Given this list of marker genes NUP42, SP3, IKBKG, NSMCE4A, SP100, HDAC7, TP53, SAFB, RNF2, PHC1, SIN3A, HIC1, RAE1, SMC3, RPA1, MRTFA, NCOA2, NCOR2, BRCA1, NOP58, HDAC1, PHC2, RING1, BLM, CDCA8, L3MBTL2, NFKB2, PGR, H4C1, NUP35, MITF, EP300, CTBP1, RANGAP1, NRIP1, NCOA1, PPARA, IKBKE, SUMO2, SMC1A, NSMCE3, DDX5, NUP88, NR1H2, NSMCE1, WRN, ZNF131, ING2, NUP85, PPARG, CBX2, RAD52, TOP1, FOXL2, CASP8AP2, VDR, NUP37, HIPK2, CDKN2A, HNRNPC, PARP1, RANBP2, TOP2B, AURKA, NR1H4 (NCBI Gene Id 9971), SATB1, HNRNPK, EIF2AK2, SEH1L, HDAC2, NUP107, PCNA, MTA1, SATB2, EID3, THRB, NUP155 (NCBI Gene Id 9631), UHRF2, PML, NR3C2, PARK7, NR5A1, PPARGC1A, NR1I2, TRIM27, NUP50, PIAS1, RELA, PIAS2, DDX17, PIAS4, NR5A2, CETN2, VHL, ZNF350, NUP188, NR1H3, HDAC4, TFAP2C, NUP62, STAG1, AR, NUP210, AURKB, POM121, CBX5, RORA, NUP153, BIRC5, CBX8, TPR, NDC1, NUP93, NSMCE2, THRA, MBD1, NUP58, TP53BP1, NUP214, XRCC4, NR3C1, XPC, NPM1, NUP54, RAD21, CREBBP, DNMT3B, TRIM28 (tripartite motif containing 28), NUP205, SUMO3, CBX4, DAXX, NUP133, STAG2, TOP2A, MDC1 (mediator of DNA damage checkpoint 1), MDM2, TFAP2A, SMC5, BMI1, ZBED1, NR2C1, NUP160, RNF168, INCENP, AAAS, POM121C, DNMT1, NUP43, SUZ12, PCGF2, TOPORS, SCMH1, RXRA, UBE2I, NUP98, SUMO1, SEC13, NR4A2, ESR1, NFKBIA, SMC6, DNMT3A, HERC2, TDG, TFAP2B, PHC3, CHD3, RARA, PIAS3, here is a description of the gene set: SUMO proteins are conjugated to lysine residues of target proteins via an isopeptide bond with the C-terminal glycine of SUMO. Proteomic analyses indicate that SUMO is conjugated to hundreds of proteins and most targets of SUMOylation are nuclear. Within the nucleus SUMOylation targets include transcription factors (TFs), transcription cofactors (TCs), intracellular (nuclear) receptors, RNA binding proteins, RNA splicing proteins, polyadenylation proteins, chromatin organization proteins, DNA replication proteins, DNA methylation proteins, DNA damage response and repair proteins, immune response proteins, SUMOylation proteins, and ubiquitinylation proteins. Mitochondrial fission proteins are SUMOylated at the mitochondrial outer membrane.<br>UBE2I (UBC9), the E2 activating enzyme of the SUMO pathway, is itself also a SUMO E3 ligase. Most SUMOylation reactions will proceed with only the substrate protein and the UBE2I:SUMO thioester conjugate. The rates of some reactions are further enhanced by the action of other E3 ligases such as RANBP2. These E3 ligases catalyze SUMO transfer to substrate by one of two basic mechanisms: they interact with both the substrate and UBE2I:SUMO thus bringing them into proximity or they enhance the release of SUMO from UBE2I to the substrate.<br>In the cell SUMO1 is mainly concentrated at the nuclear membrane and in nuclear bodies. Most SUMO1 is conjugated to RANGAP1 near the nuclear pore. SUMO2 is at least partially cytosolic and SUMO3 is located mainly in nuclear bodies. Most SUMO2 and SUMO3 is unconjugated in unstressed cells and becomes conjugated to target proteins in response to stress. Especially notable is the requirement for recruitment of SUMO to sites of DNA damage where conjugation to targets seems to coordinate the repair process.<br>Several effects of SUMOylation have been described: steric interference with protein-protein interactions, interference with other post-translational modifications such as ubiquitinylation and phosphorylation, and recruitment of proteins that possess a SUMO-interacting motif (SIM). In most cases SUMOylation inhibits the activity of the target protein.<br>The SUMOylation reactions included in this module have met two criteria: They have been verified by assays of individual proteins (as opposed to mass proteomic assays) and the effect of SUMOylation on the function of the target protein has been tested. Reactome Pathway: SUMO E3 ligases SUMOylate target proteins studied in species Homo sapiens part of: SUMOylation